The following is a description of a gene set: Peptide ligand-binding receptors Mouse Gene Set: REACTOME_PEPTIDE_LIGAND_BINDING_RECEPTORS studied in species Mus musculus, and this is the list of marker genes: Ednra, Hcrt, Sstr1, F2rl3, Ccr10, Nmur2, Sst, Ntsr1, Cxcr2, Ccl21d, Agt, Mchr1, Edn1, Nln, Pnoc, C5ar1, Cxcl1, Trhr, Gper1 (NCBI Gene Id 76854), Npffr2, Ccl21b, Cxcr1, Gpr37l1, Ccr3, Galr2, Edn3, Bdkrb1, Npy1r, Sstr2, Rxfp2, Mc5r, Prokr1, Hcrtr2, Ccrl2, Eef1ece2, Mc3r, Tac2, Fpr-rs3, Ccl9, Oprm1, F2r, Ccl1, F2rl2, C3, Trh, Ccl3, Cxcr4, Ece2, Prlh, Ccl27a, Ccl21a, Aplnr, Npbwr1, Ccl28, Cxcl10, Mc2r, Cxcl16, Ccl27b, Cx3cl1, Oprk1, Hebp1, Oprd1, Cxcl11, Npw, Npy4r, Gpr37, Kng2 (kininogen 2), Qrfp, Psap, Cxcl12, Ccl21e (C-C motif chemokine ligand 21E), Avpr1a, App, Grp, Prok2, Ccl11, Ccl21f, Prokr2, Rxfp1, Agtr1a, Tacr1, Ccl20, Sstr5, Ackr3, Ppbp, Kiss1, Edn2, Cxcl13 (NCBI Gene Id 70783), Nmu, Cck, Cckar, Penk, Sstr3, Cxcl9, Uts2b, Qrfprl, Ccr5, Bdkrb2 (NCBI Gene Id 12062), Grpr, Cxcl2, Fpr1, Ccl5, Tacr3, Fpr-rs4, Mc1r, Rln1, Npy5r, Ccl22, Xcl1, Nms, Ccl25, Prlhr, Nmb, Npff (neuropeptide FF-amide peptide precursor), Oxtr, C5ar2, Ccr4, Ppy, Oprl1, Nmur1, Cx3cr1, Fpr2, Nps, Pdyn, Galr1, Rxfp4, Galr3, Ccl6, Npy2r, Nmbr, Rln3, Cxcr3, Prok1, Cxcr6, Pmch, Brs3, Xcr1, Mc4r, Insl3, Sstr4, Insl5, Rxfp3, Fpr3, Ccr8, Ccl12, Cort, Xk, Nts, Gal, Ccl19, Pf4, Ccr9, Pyy, Apln, Uts2r, Agtr2, Npy, Ednrb, Ccl27al, F2rl1, Tacr2, Uts2, Npsr1, Kel, Ntsr2 (neurotensin receptor 2), Fpr-rs7, Npffr1, Avpr1b (arginine vasopressin receptor 1B), Avp, Ccr6, Cxcl5, Kiss1r, Anxa1 (NCBI Gene Id 319730), Tac1, Avpr2 (NCBI Gene Id 12000), F2, Npb, Hc, Oxt, Cxcr5, C3ar1, Fpr-rs6, Cxcl3, Ackr2, Ccl17, Ccr7, Cckbr, Ackr4, Hcrtr1, Pomc, Ccl4, Ece1